The following is a description of a gene set: studied in species Homo sapiens Human Gene Set: PID_TCR_RAS_PATHWAY Ras signaling in the CD4+ TCR pathway from publication Schaefer CF, Anthony K, Krupa S, Buchoff J, Day M, Hannay T, Buetow KH (PMID 18832364), and this is the list of marker genes: NRAS, MAPK3, ELK1, MAP2K1, MAP3K8, BRAF, RAF1, KRAS, FOS, PTPN7, MAPK1, HRAS, PRKCA, PRKCB